The following is a description of a gene set: Human Gene Set: GOBP_TRNA_SURVEILLANCE studied in species Homo sapiens The set of processes involved in identifying and degrading defective or aberrant tRNAs., and this is the list of marker genes: EXOSC7, ZCCHC7, EXOSC3, TRNT1, EXOSC9, EXOSC2, EXOSC8, EXOSC10 (exosome component 10)